The following is a description of a gene set: In the present study we used Affymetrix oligonucleotide microarrays to produce gene transcription profiles for the major leukocyte types in humans. This comprehensive dataset enabled us to not only establish which genes were expressed in each leukocyte type, but also which genes were expressed in each subset after activation. The used of a comprehensive dataset of gene profiles from all the major human leukocyte subsets enabled a novel and powerful means for identification of genes associated with single leukocyte subsets, or different immune paradigms. Genes down-regulated in comparison of eosinophils versus dendritic cells (DC). from publication Jeffrey KL, Brummer T, Rolph MS, Liu SM, Callejas NA, Grumont RJ, Gillieron C, Mackay F, Grey S, Camps M, Rommel C, Gerondakis SD, Mackay CR (PMID 16474395) studied in species Homo sapiens Human Gene Set: GSE3982_EOSINOPHIL_VS_DC_DN, and this is the list of marker genes: UNC119, BLMH, HPCAL1, ALG5, GTF3C5, BARD1, CBR1, CBR3, PCK2, PEMT, ZNF43, SCARB1, CTSC, PMM2, HSPB1, ITGB1BP1, ADK, ASPH, CUL4A, FASTKD1, ABCB4, FOSL1, ACOT7, PTCD1, ACO1, FBXO21, GM2A, ENO1, VWA5A, GBA1LP, QDPR, CORO1B, CCNB2, PALLD, RPN1, ATP6V1G1, REXO2, SETMAR, DPAGT1, CYP27A1, ABRAXAS2, LIMS2, ALDH1A1, ROBO3, KMO, TCEAL9, UTP3 (UTP3 small subunit processome component, NCBI Gene Id 57050), CD99, TST, PLXNB2, RAI14, SDC4, ITFG1, TFG, MAF, PEX3, ATRAID, ACOX1, METTL1, TBC1D9B, CD4, TGFBI, CBX5, ARMCX5, PSMC4, PPP1R7, PIN4 (peptidylprolyl cis/trans isomerase, NIMA-interacting 4), C2CD2, MRPL35, LPAL2, GCGR, CMC2, CD83, TRAM1, ALDH2, FAM162A, ATP5PO, CCNA1, CSNK1G3, MDH1, VANGL1, DCXR, RHEB, DYNLT1, MPV17, MCUR1, HSD3B1, ATP5F1C, ABCD4, RAB11A, CD36, NQO1, DDX10, PKM (pyruvate kinase M1/2), MDM2, ABI3BP, SIGLEC7, SLF2 (NCBI Gene Id 55719), SAMHD1, AGK, IFT74, CSTB, GRWD1, MMS19, WDR3, R3HDM1, GIMAP6, TMEM53, DCTD, NACC2, ANXA2P2, PNP, SLC31A1, CLNS1A, EHD4, SNX5 (NCBI Gene Id 27131), ATF3, MTX1, HBS1L, AIMP1, LGALS1, MFHAS1, AAGAB, LMAN2L, PPP2R3A, VAC14, VPS41, BST1, CD1D, PMP2, FLT1, ATP6V1H, TFRC, H3C11, CSTPP1, PDGFA, MRC2, FDX1, ALCAM, RNASE6, CSE1L, ZW10, UGP2, KPNA4, DAP3, INVS, FCER2, PDSS2, PCSK5 (NCBI Gene Id 96284), C1orf115, NIPSNAP1, EXOC2, SLC15A3, HIRIP3, TXNL4A, PPARG, SCD, PARN, ADO, CALML4 (NCBI Gene Id 91860), ADAP2, KDM7A, CHN2, SLC39A14, CERS6, CXCL2, CLEC10A, SESN1, GATB, TRIAP1, UBXN8, OTUB2, COPB2, PIK3C2B (NCBI Gene Id 5287), LRRC8D, HADHB, EIF4G1, CARD9, HSPA8, MRPS33, ST13, KYNU, ADCK2, HLA-DQA1, ATP5F1A, CDC42BPB, SLC2A9, CYP27B1, STAT6, IL1RN, CTNNA1 (catenin alpha 1), DUSP22, CCDC88A, OSBPL3, TRIM14, CELSR1, ARMCX1, IL17A, HEBP1, DHRS9